Given this list of marker genes RBPJ, COL7A1, GRIN1, SCN2A, KCNA1, SCN1B, APC, ARX (aristaless related homeobox), TRIM8, NOTCH1, PORCN, SIK1, NOG, NEUROD2, MAPK1, PIGP, DSP, CDKL5, ATP6V1B2, KCNN3, EOGT, DMXL2, TBC1D24, SLC32A1, PNKP, ARID1A, BCR, LRP4, GRM7, GNAO1, PIGQ, CASK, KCNH1, CRKL, SLC25A22, JUP, FIG4, DLL4, DOCK6, ARHGAP31, here is a description of the gene set: Human Gene Set: HP_ABSENT_FINGERNAIL studied in species Homo sapiens Absent fingernail Absence of a fingernail.